The following is a description of a gene set: from publication Chen Y, Wang X (PMID 31504780) studied in species Homo sapiens Genes predicted to be targets of miRBase v22 microRNA hsa-miR-2113 in miRDB v6.0 with MirTarget v4 prediction scores > 80 (high confidence targets). Human Gene Set: MIR2113, and this is the list of marker genes: B2M, FHIP1A, NBN, IDH3A, KLHL13, LHX1, GOLGA6D, LAMB3, TRIM2, MPRIP, PEX5L (NCBI Gene Id 51555), SFMBT1, MTOR, SYNPR, NCOA2, HECTD2, POU3F2, E2F8, GRIK2, RBKS, ATL1, OSBPL8, PIK3CA, TMEM70, SORCS1, SYT1 (synaptotagmin 1), RALGPS1, PPP2R5A, HIP1, DCUN1D3, STK26, ADGRL4, SPSB1, GLYATL2, NHSL3, ACSL1, CCDC88A, USP44, FN3KRP, ELL2, ZNF37A, COL3A1, MID2, SEC14L1, HAPLN1 (hyaluronan and proteoglycan link protein 1), EMC7, MDGA2, ROR1, MBD6, UBE2D2, CREB1, MYO5B, MAB21L2, STRN3, SIK2, WDR7, EBF1, CAMTA1, ANGPTL7, RDH11, MYH8, NOTCH2, CASK, RABGGTB, KCNIP3, SOWAHC, RNF103, STARD3NL, CDS1, RAD9B, CRH, NCBP1, CLOCK, FAM210A, TUB, KCNB1, SGIP1, WBP2NL (WBP2 N-terminal like, NCBI Gene Id 164684), RFX3, KAT6A, SATB1, TRPC3, PTBP3, FBXO33, GCC1, MED26, ANKRD27, ZBTB18, AIG1, ZFP36L2, TNKS, DUSP16, PROX1, RNF139, CACNB4, NAA15, PDXDC1, PLEKHA5, SULF2, GTDC1 (glycosyltransferase like domain containing 1), CDH2, SCAI, CERT1, YES1, ASXL3, BTG2, CBL, GLRA2, SOCS1, COL10A1, FGD1, PKN2, SLF2, GOLGA6C, MYH2, TMX1, ADIPOR2, ZNF559-ZNF177, GABBR2, KIF21B, MXI1, MOB3C, TRHDE, CLEC5A (C-type lectin domain containing 5A), LITAF, BBX, PHLPP1, CDH8, TAS2R20, PURG, PPTC7, DNAI1, FMR1, RICTOR, ZNF385A, KCND1, CHUK, EPC1, RIPOR2, ATRN, SORBS1, CPM, SIX4, RIN2, AHDC1, SYT13, RBL1, FYB1, MARK1, PMEPA1, E2F5, ADAM23 (NCBI Gene Id 8745), EIF4G2, SEMA6D, IGFBP3, LRP1B, ADGRG6, RELN, ZNF585A, TSPAN5, CPEB3, ERBB4, BICC1, RNF38, FBXO8, CHST4, PIM1, SHC1, WWC2, JADE1, ZNF521, TBPL1, GOLGA6B, LRCH1, ARSD, PLCB4, ABCC9 (ATP binding cassette subfamily C member 9), MYH1 (NCBI Gene Id 4619), ITGAX, LIN52, ATF2, PON2, PPARA, IFNL1, CHFR, CASTOR2, ADGRL2, SNTB2, GABPA, ARID4B, HIPK2, POGLUT3, FCHSD2, KDM3B, INO80D, GOLGA8B, FRMD3, KIRREL3, KCNQ5, FGF13, ADRB1, UBE2D1, USP32, OMG (NCBI Gene Id 4974), STAM2, BRCA1, KLHL29, GOLGA6A, SH3KBP1, THBS1, PURA, WDR44, PIK3C2A, SLC17A6, CNTNAP2, RTN3, ADAMTSL1, ANKRD12, USP15, DIP2C, ZNF697, GPR161, PPP1R11, FAM20B (NCBI Gene Id 9917), CCDC6, SLC12A5, TBR1 (T-box brain transcription factor 1), ACTN1, SYNJ1, EBF2, NRXN1, HOMER1, MBNL3, SGCD, NAMPT, DSCAML1, GOLT1B, SLAIN2, TRIM9, LYST, CSDE1, RAB23, ABR, STK3, NRK, GRM3, MAP4K3, AGO1, SUZ12, SCN2A, FBN2, THSD7A, EIF2AK3, FANCB, MBTD1, NAV3, RTL4, GOLGA8A, KIF16B, APBA1, TRAK2, USH2A